Given this list of marker genes ACAT1, IDH2, SDHB, FXN, SIRT3 (sirtuin 3), SDHC, SDHAF1, NFS1, SDHAF4, CS, ISCA1, ISCA2, CSKMT, LYRM4, SDHD, ACO2, ISCU, SDHA, SDHAF3, SDHAF2, here is a description of the gene set: species: Homo sapiens Human Gene Set: REACTOME_MATURATION_OF_TCA_ENZYMES_AND_REGULATION_OF_TCA_CYCLE Maturation of TCA enzymes and regulation of TCA cycle